Given this list of marker genes SBF2, PLAUR (NCBI Gene Id 5329), ADAM9, CLDN7, NPM1 (NCBI Gene Id 4869), SEPTIN2, HOMER1, ABHD14A, PON3, CRYBB2, CD19, IL10RA, RALGPS2, UBL3, PKIB, HSD17B11, OXT, PSPC1, MAP3K8, HSDL2, CNIH4, PLTP, TXNDC17, NUDT19, HYCC2, CNN3, MTM1, NHSL3, PPP1R21 (NCBI Gene Id 129285), RIDA, HCK (NCBI Gene Id 3055), CHD1, TGIF1, LRRC58, DCT, TMEM123, GCM2, OAT, PRKCE, RAB31, KCTD12, TACR2, LMO2, CIITA, AHCY, TACSTD2, FDX1, SLC25A15, PML, PRKCD, SLC31A1, SLC38A2 (NCBI Gene Id 95454), ITGA4, CCT6A, MAN1A1, ZC3H12C, TRNT1, SMIM14, SLC32A1, CD22, POU2AF1, PIM1, RBM25, ITGA6, PLAC8, PSMD14, MCL1, MAB21L2, VCL, CXXC5, CEP89, TRAPPC12, TUBB6, EPS15, IRAK1, TEP1, BLK, SLC4A1 (solute carrier family 4 member 1 (Diego blood group)), CD38, LYN, HUS1, PLBD1, MYADM (NCBI Gene Id 91663), HLA-DOB, HHEX, RIPOR2, MPEG1, MAP3K1, PTS, HK2, IMPDH2, ANXA2, TFAM (NCBI Gene Id 8033), GABRA3 (gamma-aminobutyric acid type A receptor subunit alpha3), PRDX4, INHA, LIMD1, WEE1, SQLE, KPNA2, LGALS4, LAMP2, PRPS2, CPNE6, UBE3A (ubiquitin protein ligase E3A), NAP1L1, SSPN, ABCB7, PLD4, CFAP20, GBP4 (NCBI Gene Id 115361), SLC7A7, GCSH, UBE2E1, MYC, TUBA1A, YBX3, RASA3, CCR1, EBF1, NFIL3, RASD1, GCOM1, GPHN, S100A10, EPCAM, TSPAN13, EPS8, EIF2AK4, P2RX4, MRTO4, GLO1, ADSS1, FAH, TPD52, POLE3, GPR137B, SAA1, SERPINI1, SLC16A7, BCAP29, XPOT, PLSCR1, C9orf85, RYR1 (NCBI Gene Id 906), TPST1, CASP9, MTCH1, BAG2, PEPD, MCOLN2, RABGGTB, MFSD14A, TUBB3, KLF2, ERO1B, CTSH, MYO7A (NCBI Gene Id 4647), IGHM (NCBI Gene Id 3507), RAP1A, SELL, SYK, NPAS1, KLF4, S100A6, SCD, TCF4, LIPC, LRRC8A, ARHGAP21, RSU1, NEDD4L, KCNN4, CPSF2, CCDC28B, LITAF, GGA2, NID1, PHTF2, SYPL1, GNB3, RGS14, EIF2AK3, PKIG, ARL3, MYL6, MGAT1, MGST1, URM1, TIPARP, DAG1, DRAM2, CTSC, SERP1, MYO5A, EVI2A, DMTF1, KIAA0930, CASP1, CLIC4, here is a description of the gene set: Genes up-regulated in CD8 T cells: KLRB1 high versus KLRB1 int. Human Gene Set: GSE33424_CD161_HIGH_VS_INT_CD8_TCELL_UP We used microarray to compare gene expression between CD161++/CD161+/CD161-CD8+ T cells from human cord blood. species: Homo sapiens from publication Walker LJ, Kang YH, Smith MO, Tharmalingham H, Ramamurthy N, Fleming VM, Sahgal N, Leslie A, Oo Y, Geremia A, Scriba TJ, Hanekom WA, Lauer GM, Lantz O, Adams DH, Powrie F, Barnes E, Klenerman P (PMID 22086415)